The following is a description of a gene set: species: Homo sapiens Human Gene Set: GOBP_NEGATIVE_REGULATION_OF_CYTOKINE_PRODUCTION_INVOLVED_IN_IMMUNE_RESPONSE Any process that stops, prevents, or reduces the frequency, rate, or extent of cytokine production contributing to an immune response., and this is the list of marker genes: TBX21, APOA2, SMAD7, HLA-F, ANGPT1, ACP5, AXL, APOA1, CD96, NLRX1, CUEDC2, HFE, ATG9A, BCL6, SLAMF1, FOXP3 (NCBI Gene Id 50943), TGFB1, JAK3, RABGEF1 (NCBI Gene Id 27342), EPX, TWIST1, LILRB1, IFNB1, TNF, PRG2, IL10, XCL1, LILRB4, ARG1, BST2, TGFB3, IRAK3, MIR302A, IFNA2, TGFB2